The following is a description of a gene set: Reactome Pathway: TRAF6 mediated IRF7 activation studied in species Mus musculus part of: DDX58/IFIH1-mediated induction of interferon-alpha/beta electronically inferred by orthology from the curated human pathway This event has been computationally inferred from an event that has been demonstrated in another species.<p>The inference is based on the homology mapping from PANTHER. Briefly, reactions for which all involved PhysicalEntities (in input, output and catalyst) have a mapped orthologue/paralogue (for complexes at least 75% of components must have a mapping) are inferred to the other species., and this is the list of marker genes: Irf3, Irf7, Ep300